The following is a description of a gene set: Genes up-regulated in HMLE cells (immortalized nontransformed mammary epithelial) cells after loss of function of E-cadhedrin (CDH1), which was achieved either by RNAi knockdown or by expression of a dominan-negative form of CDH1. Human Gene Set: ONDER_CDH1_TARGETS_3_UP from publication Onder TT, Gupta PB, Mani SA, Yang J, Lander ES, Weinberg RA (PMID 18483246) Loss of the epithelial adhesion molecule E-cadherin is thought to enable metastasis by disrupting intercellular contacts-an early step in metastatic dissemination. To further investigate the molecular basis of this notion, we use two methods to inhibit E-cadherin function that distinguish between E-cadherin's cell-cell adhesion and intracellular signaling functions. Whereas the disruption of cell-cell contacts alone does not enable metastasis, the loss of E-cadherin protein does, through induction of an epithelial-to-mesenchymal transition, invasiveness, and anoikis resistance. We find the E-cadherin binding partner beta-catenin to be necessary, but not sufficient, for induction of these phenotypes. In addition, gene expression analysis shows that E-cadherin loss results in the induction of multiple transcription factors, at least one of which, Twist, is necessary for E-cadherin loss-induced metastasis. These findings indicate that E-cadherin loss in tumors contributes to metastatic dissemination by inducing wide-ranging transcriptional and functional changes. species: Homo sapiens, and this is the list of marker genes: KCNMA1, TSC22D3, TCEA2, S100A8, CRIP2, CYP1B1 (NCBI Gene Id 1545), STC2, ZBTB16, ALDH6A1, MAGED1, KLF9, MAGED2, KDELR3, RNASE4, WIPI1, PRKCA, LEPR, FTL